Given this list of marker genes Fanca, Prdx4, Ptgdr2, Eif2s2, Rhbdd1, Dmrt1, Ptgds, Hpgds, Il18, Larp7, Cib1, Src (NCBI Gene Id 99351), Rspo1, Uchl1, Spink2, here is a description of the gene set: species: Mus musculus Mouse Gene Set: GOBP_GERM_CELL_PROLIFERATION The multiplication or reproduction of germ cells, reproductive cells in multicellular organisms, resulting in the expansion of a cell population.